Given this list of marker genes EIF4H, RASA1, PDE11A, CAVIN1, TGFB3, MAT2A, GANAB, FLNA, PRDM16, BGN, ARFGEF2, SALL4, NKAP, FBXO11, TGFB2, TONSL, TREX1 (three prime repair exonuclease 1), TGFBR1, RFC2, FBLN5, PTEN, RNASEH2C, ERCC6, TMEM67, PTPN22, NSMCE2, PLOD1, LMNA, PBX1, LUZP1 (NCBI Gene Id 7798), STX1A, SMAD6, EXT2, HEY2, BUD23 (BUD23 rRNA methyltransferase and ribosome maturation factor), IFT140, KCNH1, NDE1, ALDH18A1, B3GAT3, NF1, FKBP6, IPO8 (importin 8), RNASEH2A, ERMARD, POLR1A, APOA1, ZMPSTE24, FOCAD, PRKCZ, LSM11, TGFBR2, CRB2, HNRNPK, PCNT, C12orf57, MYLK, PTPN11, ENG, SEC63, TPM2, CHD7, ERCC8, MKS1, SMAD4, SOX10, EFEMP2, MYH11, ABL1, TMTC3, MNX1, RIN2, COL4A1, BCR, PRKG1, RAP1B, VPS37D, GTF2IRD2, PEX12, AFF4, NOTCH1, PRKAR1A, PIGN, ALDH1A2, WDR19, COL1A1, CARS1, KANSL1 (KAT8 regulatory NSL complex subunit 1), EXT1, MAPK1, MID1, NODAL, EPHB4, ZFX, ELN, LOX, ATP2B1, UBE4B, SMAD2, COL1A2, COL5A2, TGFBR3, CLIP2, HSPG2, BRF1, CRKL, TAF4, BAZ1B, LIMK1, THBS2, GAA (alpha glucosidase), GJA5, RPL10, APC2, GATA5, MED12, RNASEH2B, SLC25A24, RAF1, PKD2, TMEM270, TNNT2, SPTBN1, CASZ1, UBR1, COL5A1 (collagen type V alpha 1 chain), MFAP5, FARSB, SEMA3E, GJA8, LRP5, SLC2A10, FLNB, LTBP1, DNAJB11, PKP2, ADAMTS19, COL3A1, GABRD, SPECC1L, ACTA2, NPR3, PDPN, NSD1, NKX2-5, PKD1, IFIH1, SPEN, ALG5, ATP6V1A, THSD4, METTL27, MAP1B, B3GALT6, LYN, TSC1, PLOD3, GTF2I, ATP7A, IL12B, FOXE3, MMP23B, ATP6V1E1, IFNG, BRAF, NOTCH3, ANGPTL6, PAM16, HLA-DRB1, ALG9, MYH3, ROBO4, ADAR, RNU7-1, THSD1, NCF1, LTBP4, BICC1, STAT3, OFD1, P4HA2, FBN2, SMAD3, SKI, PGM3, RERE, DNMT3A, GMPPB, MYPN, KCNAB2, DPH5 (diphthamide biosynthesis 5), TAB2, PRKCSH, DNAJC30, ARF1, TBL2, MLX, FBN1, CHRNG (cholinergic receptor nicotinic gamma subunit), GTF2IRD1, AEBP1, HGD, TSC2, SAMHD1, STAT1, GGCX, CHST3, NEDD4L, NOD2, PPP1CB, FMR1, RAI1, HLA-B (major histocompatibility complex, class I, B), TPM3, NPPA, here is a description of the gene set: studied in species Homo sapiens Abnormal outpouching or sac-like dilatation in the wall of an atery, vein or the heart. Human Gene Set: HP_VASCULAR_DILATATION Vascular dilatation